The following is a description of a gene set: studied in species Homo sapiens Progressive impairment of function of motor axons with muscle weakness, atrophy, and cramps. The deficits are length-dependent, meaning that muscles innervated by the longest nerves are affected first, so that for instance the arms are affected at a later age than the onset of deficits involving the lower leg. Human Gene Set: HP_MOTOR_AXONAL_NEUROPATHY Motor axonal neuropathy, and this is the list of marker genes: PNPLA6 (NCBI Gene Id 10908), AIFM1, VRK1, HMBS, SPTLC1, WDR48, HNRNPA2B1, VCP, ATL3, SCO2, GAN, HARS1, KLC2, C19orf12, MORC2, KCNK9, TRAPPC11, EXOSC9, SPTBN4, OPA1, PEX10, LMNA, SPTAN1, RTN2, PLEKHG4, GMPPA, SLC12A6, RNU4-2, AGTPBP1, XK, COASY, KPNA3, HNRNPA1, HINT1, VWA1, SPTLC2, TBCD, SPG7, WARS1, ATL1, AAAS